The following is a description of a gene set: Catalysis of the transfer of an acetyl group to a carbon atom on the acceptor molecule. Mouse Gene Set: GOMF_C_ACETYLTRANSFERASE_ACTIVITY species: Mus musculus, and this is the list of marker genes: Acaa1a, Acat2, Acaa2, Gcat, Acat1, Hadhb, Acaa1b, Acat3